Given this list of marker genes NGFR, NGF, SMPD2, here is a description of the gene set: Reactome Pathway: Ceramide signalling part of: p75 NTR receptor-mediated signalling species: Homo sapiens In certain cell types, ligand binding to p75NTR leads to ceramide production, which can mediate either cell survival (e.g. in noecotical subplate neurons) or apoptosis (e.g. in oligodendrocytes). Low levels of ceramide are also able to stimulate axonal outgrowth in hippocampal neurons.